Given this list of marker genes CDK5RAP1, VARS2, DTD2, YRDC, TARS2, AARSD1, IARS1, DTD1, VARS1, DNAJC2, LARS1, RPS5, IARS2, AARS2, PRORSD1P, AARS1, GATC, LARS2, here is a description of the gene set: Any process that modulates the ability of the translational apparatus to interpret the genetic code. Human Gene Set: GOBP_REGULATION_OF_TRANSLATIONAL_FIDELITY species: Homo sapiens